Given this list of marker genes NHSL1 (NHS like 1), INO80D, CTNND1, SETBP1, ABCB5, ID4, JADE3, LOX, PEAK1, SIRT1, SLK, HNRNPR, SIK2, TNPO1, SLC25A53, ARFGEF1 (ADP ribosylation factor guanine nucleotide exchange factor 1), SV2C, CCND1, C2CD2, OLFM3, MAN1A2, ZFPL1, GBP3, P2RY1, SNX16, PGM2L1, CDH2, UBL3, ITSN2, FOSL1, ZNF680, ADGRL4, PIP4P2, MEX3C, CSNK1G3, RALGPS2, ITPRID2, PIK3C2A, SLC2A2, RAP1A, MIDEAS, SPOP (speckle type BTB/POZ protein), ZNF254, TRIM48, PZP, PRG4, KERA, SCARB2, NXF1, ELL, CXADR, DIRC1, ACVR2A, MOSMO, ASH1L, UCHL3, ZNF195, SLC23A2, IFNGR2, LARS1, FYB1, ATG9A, EID1, DSTN, AP1S2, WIPF2, CDKN1B, PICALM, FRS2, ZNF92, YWHAG, MYO1C, DOCK7, SOX30, ATF7, KRAS, DTNA, OSBPL8, CTNNA3, RAPGEF4, THBD, JADE1 (jade family PHD finger 1), TOGARAM1, ZNF257, KPNA4, ARHGAP6, TNFRSF1A, UBP1, ECM1, EIF5, TOM1L2, ANLN, MED13L, ADRB2, CSRP2, TMEM63B, RFX7, TAOK1, SMAD4, SOST, OSBPL3, SNX12, PCYT1A, LAMA1, ZNF43, NR3C2, HDLBP, RAB11FIP1, HSBP1, CDC7, PKN2, ITGA5, FERRY3, ITGA4, TMEM65, KCTD5, RPS6KC1, KDELR1, MTX3, DMRT3, DDX6, RMND5A, BRINP1, MAP4K3, HMMR (hyaluronan mediated motility receptor), AEBP2, FXR1, TSC22D2 (TSC22 domain family member 2), ZFYVE16, LHFPL5, CYBRD1, GABRB2, PCDH17, ECM2, RO60, NUFIP2, MBTD1, BAHCC1, CLIC4, KCNJ8, DSTYK, RBSN, CEP70, FANCD2OS, SBDS, GSE1, VEGFC (vascular endothelial growth factor C), ADAM30, DNAJC21, FAM131B, PRR9, KCTD3, ZNF596, VPS26A, SP110, TGIF2, FAM8A1, SLA, PBX3, VPS37A, UBTD2 (ubiquitin domain containing 2), ITGA8, TMEM181, SPPL3, CLDND1, USP38, PPIL4, GABRA6, APBB2, TRPS1, SOS1, RHOQ, ZNF793, NFKBIE, SHOC1, DYNLT1, KLHL41, RPL31, SFMBT1, CUX1, NR3C1, TRIM49D2, DRAM1, SLC38A4, BNIP3, RELCH, FSCN3, ETV6, GNG10, SAMD8, VCAN, DNAJC25-GNG10, DVL1, BBX, ALCAM, ZNF716, IGF2BP3, ETV1 (NCBI Gene Id 221810), DDR1, PKHD1L1, HNRNPK, ZNF248, YES1, MTFR1, PANK2, MAP4K4, ZNF506, ATXN1, AKAP6, QRICH1, KCTD12, RAB12, here is a description of the gene set: from publication Chen Y, Wang X (PMID 31504780) Genes predicted to be targets of miRBase v22 microRNA hsa-miR-122b-5p in miRDB v6.0 with MirTarget v4 prediction scores > 80 (high confidence targets). Human Gene Set: MIR122B_5P studied in species Homo sapiens